The following is a description of a gene set: Interleukin-21 (IL-21) is a pleiotropic cytokine that induces expression of transcription factor BLIMP1 (encoded by Prdm1), which regulates plasma cell differentiation and T cell homeostasis. We identified an IL-21 response element downstream of Prdm1 that binds the transcription factors STAT3 and IRF4, which are required for optimal Prdm1 expression. Genome-wide ChIP-Seq mapping of STAT3- and IRF4-binding sites showed that most regions with IL-21-induced STAT3 binding also bound IRF4 in vivo, and furthermore, revealed that the noncanonical TTCnnnTAA GAS motif critical in Prdm1 was broadly used for STAT3 binding. Comparing genome-wide expression array data to binding sites revealed that most IL-21-regulated genes were associated with combined STAT3-IRF4 sites rather than pure STAT3 sites. Correspondingly, ChIP-Seq analysis of Irf4_/_ T cells showed greatly diminished STAT3 binding after IL-21 treatment, and Irf4_/_ mice showed impaired IL- 21-induced Tfh cell differentiation in vivo. These results reveal broad cooperative gene regulation by STAT3 and IRF4. Human Gene Set: GSE19198_CTRL_VS_IL21_TREATED_TCELL_6H_UP Genes up-regulated in T cells: control (0h) versus IL21 treatment for 6h. species: Homo sapiens from publication Kwon H, Thierry-Mieg D, Thierry-Mieg J, Kim HP, Oh J, Tunyaplin C, Carotta S, Donovan CE, Goldman ML, Tailor P, Ozato K, Levy DE, Nutt SL, Calame K, Leonard WJ (PMID 20064451), and this is the list of marker genes: ARAP2, FIS1, SIGLEC1, EHD1, CUL9, EPOP, IFITM2, MAP3K1, MPEG1, MYC, GINS1, NAIP, NECAP2, QTRT1, GATM, FCGR2B, WASF2, SCARB1, FLI1, IDH3G, IMP4, BLVRB, HRH1, P2RY12 (purinergic receptor P2Y12), SUCLG1, CCT3, GMFG, IL18BP, HSPA6, ATP8B4, MRPL15, CLIP2, SRM, PARL, EHD4, CSF2RB, NRP2, FCER2, CXCL2, SNU13, TCF4, BTF3L4, NUCKS1, THOC1, HCST, EXT1 (exostosin glycosyltransferase 1), VARS1, CD48, TNFAIP2, TSPAN4, TRAF3, C9orf72, IL2RG, GIMAP5, POLD2, MRPL24, ANKS1A, PFKP, PDLIM2, PIK3R6, FRMD4B, DCTPP1, CYC1, GPI, BLVRA, P2RY14, CDK6, LILRB2, TBCB, PIGX, AIF1, PHTF2, ENTPD6, SETD7, SLC25A5, SLITRK4, SELPLG, DAP, CD209, SLC25A12, RNF144B, MOB1A, MGRN1, MLLT6, GALK1, MOB3C, OXCT1, ITSN1, DTD1, MTCL2, PFKM, TNFRSF1A, SLCO3A1, OGDH, TXN2, DGLUCY, SLC16A7 (NCBI Gene Id 9194), TRAP1, STING1, JPT2, NDUFV1, CORO1A, TRERF1, RAN, TTYH2, PPARGC1B, NME1, SLC46A3, RNF128, ARHGAP4, ARHGAP45, CCDC85B, TNIP1, ATP5F1D, HLX, FAR2, FIGNL1, IFI16, PRDX4, RBPJ, SFXN4, MCM6, SNX6, RUVBL1 (RuvB like AAA ATPase 1), TUBA1A, CMAHP, BCAR3, NABP1, CBR3, CYTH4, DARS1 (NCBI Gene Id 1615), DHRS9, EMB, ADAT2, SECTM1, ST3GAL5, PRMT1, ATP5F1B, TRIM32, TMOD2, CD33, UROS, ATM, TBC1D14, TUBB, BIRC3, METRNL, FNBP1, SYNE1 (spectrin repeat containing nuclear envelope protein 1), OAS2, PLEK, OXLD1, INPP5D, PRSS23, AFF1, IFITM3, CCL13, IPO4, DCLRE1B, COQ8A, GNAI2, PAPSS2, RNF125, UBAC1, SCFD2, CDC123, PTPA, PRKACB, IL10RA, TBC1D2B, MIF, CHST15, NAMPT, NRROS, GGTA1, JAML, CAPNS1, SNAP23, CYSLTR1, XPO6, EMILIN2, JUP, SRI, DAGLA, MPP1, CCL23, DNPH1, NCF4, MARCHF1, BZW2, ARL2, RAB33A, SULF2, NOB1, P2RY13 (NCBI Gene Id 53829), PDCD4, RCSD1, XXYLT1, AHCY, LRRC25